Given this list of marker genes Btn2a2, Prnp, Pdcd1lg2, Arg1, Lilrb4a, Cd274, Scrib (scribbled planar cell polarity), Lrrc32, Rc3h1, Ido1, Prkar1a, Casp3, Laptm5, Crtam, Lilrb4b, here is a description of the gene set: studied in species Mus musculus Any process that stops, prevents or reduces the rate or extent of activated T cell proliferation. Mouse Gene Set: GOBP_NEGATIVE_REGULATION_OF_ACTIVATED_T_CELL_PROLIFERATION